Given this list of marker genes PANK2, ABCD4, AOPEP, TIMM8A, TOR1A, EPG5, PRNP (prion protein (Kanno blood group)), here is a description of the gene set: Involuntary flexion or extension of the arms and legs. Human Gene Set: HP_ABNORMAL_POSTURING species: Homo sapiens Abnormal posturing